Given this list of marker genes Spg21, Gdf7, Nrg3 (neuregulin 3), Wnt4, Kras, Bdnf, Zfp106, Tiam1, Nup62, Fat4, Rala, Ghrhr, Rnf115, Wdr54, Plcg1, Bmncr, Tgfbr2, Nkx3-1, Ins1, Dok5, Ngef, Blvra, Pdgfrb, Dab2, Anks1, Mir210, Hap1, Lox, Il1b (NCBI Gene Id 16176), Sh2d6, Egf, Mst1r, Flt4, Psen2, Bmper, Gas6, Shkbp1, Bcr, Inhbb, Tet1, Sh2d3c, Itgb5, Mir875, Tgfa, Myoc, Nup93, Pelo, Fkbp1a, Fstl3, Pik3cd, Samd10, Mir744, Gpc1, Ncl, Gpr21, Myorg, Crim1, Tgif1, Nrep, Npr1, Mir7-2, Rbpms, Stat5b, Rhoq, Runx2, Lrp4, Ppm1l, Ncoa5, Dll1, Pid1, Ltbp4, Wwtr1, Pdcd6, Dok4, Spry4, Agr2 (anterior gradient 2), Zmiz1, Tiparp, Hip1, Serpina12, Emilin1, Col4a3, Socs2, Gdnf, Cblc, Ccl2, Mir494, Tgfbr3l, Agrn, Vsir, Efnb1, Rab14, Megf8, Foxc2, Robo1, Blvrb, Pik3r1, Hif1a, Neu3, Tmprss6, Zeb2, Nlk, Fgf3, Ephb3, Veph1, Gp6, Lgmn, Rps6kb1, Plekha1, Ovol2, Wasf1, Gper1 (G protein-coupled estrogen receptor 1), Crb2, Nfia, Myof, Ift80, Snca, Zfp950, Nog, Snx6, Twsg1, Frs3, Mvb12b, Zfp703, Schip1, Fbxw8, Casp3, Dcn, Fbn2, Strap, Ryr1, Vwc2, Rtn4, Gucy2f, Dlx5, Flt1, Dmrt1, Cbl, Ptp4a3, Zfp451, Mertk, Appl1, Lat, Bmp8a, Mmp9, Ndrg4, Men1, Skil, Gdf11, D130043K22Rik, Ptpn2, Cidea, Igfbp5, Dlx3, Bcl9l, Hhip, Fgf17, Smoc2, Lrrc32, Cdh3, Prkcd, Syk, Socs4, Ntf5, Gkap1, Abl2, Stat6, Rnf111, Adipor1, Ski, Ptprr, Irs2, Mir16-1, Onecut2, Sfrp2, Bmp5, Smpd3, Acvr1, Sh2b3, Fut8, Pin1rt1, Efna2, Flrt1, Smurf2, Stat5a, Col3a1 (collagen, type III, alpha 1), Hes5 (NCBI Gene Id 15208), Dkk1, Efnb2, Flrt3, Smad9, Nrp2, Lrg1, Fgf18, Ralb (v-ral simian leukemia viral oncogene B), Gnai2, Marcks, Ryk, Wnt3a, Sorbs1, Ppp2r5d, Gata3, Map2k5, Nrtn, Ero1a, Nppc, Slc39a14, Gpld1, Lif, Gcnt2 (glucosaminyl (N-acetyl) transferase 2 (I blood group)), Angpt1, Pdgfa, Zfyve27, Ulk1, Rassf2, Adam9, Alkal1, Fgfrl1, Itgb1, Ceacam2, Fgf22, Snx5, Notch2, Lrig2, Sulf2, Ptpn1, Ar, Rgma, Cdkn1c, Rbpms2, Rbpj, Fgf7, Ros1, Rabgef1, Ephb4, Tmem204, Chst11, Mup5, Tmem100, Txnip, Brms1, Itga3, Zfand5, Pdgfc, Gng7, Ntrk1, Ptk2b, Hjv, Nkx2-1, Dstyk (dual serine/threonine and tyrosine protein kinase), Musk, Lgals9, Tbx20, Fgf6, Sh2b2, Ahi1, Parp1, Nfatc4, Ptprj, Mir125a, Tie1, Suds3, Hspa5, Shc4, Rac1, Grb10, Dnai1, Mapk14, Aspn (asporin), Esr2, Mirlet7d, Hbegf (heparin-binding EGF-like growth factor), Cblb, Mapkapk2, Erfe, F7, Sulf1, Lcp2, Erbb3, Inpp5k, Rapgef2, A1bg (NCBI Gene Id 223599), Pdk4, Sap30, Tmem119, Fgf20 (fibroblast growth factor 20), Ahsg, Sesn3, Fzd4, Map1lc3a, Efna5 (ephrin A5), Ndst1, Arid4a, Rbbp7, Fgfr2, Srsf3, Jcad, Stub1, Tgif2, Vwc2l (NCBI Gene Id 320460), Epha10, Ss18, Scx, Npr2, Pou1f1, Gucy2g, Mup2, Mir329, Nepn, Nr4a3, Tek, Lemd3, Dusp22, Axin1, Sptbn1, Gfra4 (NCBI Gene Id 99308), Phf14, Atf2, Insrr, Adissp, Synj2bp, Ep300, Mir25, Rnf126, Slc2a4, Atp1a3, Acvr2a, Chn1, Zc3h3, Srebf1, Lef1, Pten, Slc2a10, Jak2, Ntrk2, Hgf, Adipoq, Psen1, Tgfb3, Myo1c, Adgra2, Lemd2, Rapgef1, Trp53, Erbb4, Fam89b, Rarres2, Alkal2, Grem2, Fasl, Arid5b, Spred1, Enpp1, Itga1, Mir23a (NCBI Gene Id 387216), Pin1, Apln, Comp (cartilage oligomeric matrix protein), Ints9 (NCBI Gene Id 52529), Mapk1, Smarcc1 (NCBI Gene Id 20588), Agt, Grb2 (growth factor receptor bound protein 2), Itgb6, Mirlet7a-1, Gab2, Pik3r3, Bmp8b, Il17f, Glg1, Fgf16, Tcf7l2, Hck, Fgf14, Mbd5, Igf1, Efna3, Fut7, Akap4, Tob1 (transducer of ErbB-2.1), Pgf, Sos1, Chrdl1, Tspan32, Pmepa1, Nanog, Rab7, Pxn, Gsk3a, Pdgfb, Ror2, Cpne3, Fyn, Dnm2, Sap130, Cripto, Ift88, Map2k1, Stmn1, Pip4k2c, Yes1, Atxn7, Fgfr3, Clec14a, Mstn, Tradd, Iqgap1, Sirt1, Ccn1, Cdkn2b, Efs, Ghr, Mir7-1, Pigr, Nrp1, Stat3, Numa1, Jak3, Dok6, Zdhhc16, Mtmr4, Bmpr1a, Opa1, Zic2, Pakap, Prkd2, Apc, Pik3r2, Zfp423, Grb14, Dok3, Tsc22d1, Dand5 (NCBI Gene Id 23863), Obp2a, Dab2ip, Appl2, Hhex, Fgf2, Tgfb2, Nrg2, Zfand2b, Ldlrad4, Chmp6, Bmp7, Cd2ap, Bcar3, Stk11, Gucy2e, Usp15, Gucy2c (guanylate cyclase 2c), Spry1 (NCBI Gene Id 24063), Snx1, Tfap2b, Hdac1 (NCBI Gene Id 630524), Fbxl15, Mvb12a, Tyro3, Smad5, Htra1, Ucma, Frk, Sox9, Nck2, Lmtk2, Csrnp1, Prkd1 (protein kinase D1), Map3k1, Irs3, Bcar1, Ptk2, Irs1, Pbld2, Fuz, Bace1, Gigyf1, Fstl5, Csf1r, Rela, Smad2, Kcp, Kank1, Tgfb1i1, Dusp3, Il12a, Fgf15, Usp9x, Kl, Hmga1, Col4a2, Flcn, Lifr, Sap30l, Farp1, Cited1, Agtr2, Git1, Ube2o, Mir145a, Ing1, Rhbdf1, Col4a1, Hgs, Amh, Tcf4, Rgs14, Vegfa, Foxd1, Ctdspl2, C1qtnf12, Tgfbr1, Prkcz, Hras, Slc9a6, Snw1, Igfbp4, Sdcbp, Slc39a5, Cdk5r1, Prkcb, Sort1 (NCBI Gene Id 99747), Shcbp1, Afap1l2, Sfrp4, Nptn, Rhbdf2, Slc31a1, Bmp4, Egfr, Ptprt, Mmrn1 (NCBI Gene Id 70945), Stap1, Mirlet7f-2, Dbx2, Sipa1l1, Xbp1, Myo1e, Cd59a, Adgrg1, Scube3, Ppp2r5b, Atxn1, Zcchc12, Esm1, Hipk2, Cfc1, Blk, Crebbp, Akt1, Ing2, Lep, Socs7, Fstl1, Nrg4 (neuregulin 4), Flt3, Wfikkn2, Rps6kb2 (ribosomal protein S6 kinase, polypeptide 2), Anks1b, Prmt1, Gdf5, Eid2, Pdk2, Ptpn12, Myocd, Tmem53 (transmembrane protein 53), Ffar3, Klk8, Pdgfra, Hesx1, Msx2, Zfp640, Selenon, Gdf2, Lyn, Tfap2a, Bmp2, Ltk, Osbpl8, Ptgir, Inppl1, Efna1, Snx25, Adam10, Msx1, Amhr2, Egr1, Pml, Shisa2, Plce1, Ccdc88a, Ceacam1 (CEA cell adhesion molecule 1), Cd63, Col4a5, Kdr, Itga5 (NCBI Gene Id 16402), Igfbp3, Fer, Tsg101, Skor1, Ndn, Sostdc1, Eif4ebp1, Foxo4, Arrb2, Cadm1, Pdpk1, Sema6a, Zfp592, Cav3, Trim33, Grb7, Leprotl1, Caml, Fgf21, Ppara, Kit, Trim71, Fos, Tns2, Mapk8, Braf, Pik3ca, Igf2, Map2k2, Mzb1, Vegfc, Hpgd, Cdh13, Rhod, Prdm16, Itga8, Efemp1, Ret, Smad1, Btc, Ctsd, Epha2, Ptprf, Ercc2, Socs5 (NCBI Gene Id 69052), Itgb8, Cass4, Tspan9, Mir122 (NCBI Gene Id 387232), Wfikkn1, Mup3, Spi1, Col1a2, Csnk2b, Foxc1, Ngly1, Fgr, Trps1, Mmp14, Epha5, Cyfip2, Pdap1, Nedd9, Gfra3, Efna4, Tyk2, Adrm1, Angpt4, Cul7, Mup1, Thbs1, Cnmd, Ndel1, Klb, Col6a1, Gata6, Fam83g, Mcemp1, Creb1, Akt1s1, Fgf8, Nppb, Lats1, Ngf, Furin, Adgre4, Pbld1, Fam20c, Dlx1, Il17rd, Cilp, Igfbp6, Smad4, Zfp128, Gpc3, Fshr, Fam83a, Tgfbr3, Itgb3, Tnf, Cnot9, Onecut1, Bex1, Akap3, Ddx5, Fermt1, Elapor2, Ctnnb1 (catenin beta 1), Abl1, Smad3, Mir143, Tnfaip6, Stxbp4, Fzd1 (NCBI Gene Id 14362), Smad7, Slc2a8, Gpr155, Arid4b, Trim72, Gfra1, Nrg1, Mir382 (microRNA 382), Jak1, Lrp1, Leprot, Pip4k2a, Nck1 (non-catalytic region of tyrosine kinase adaptor protein 1), Sh2b1, Spred2, Col1a1 (collagen, type I, alpha 1), Angpt2, Ltbp1, Inhba, Fnta, Sin3a, Bmp10, Fgfbp3, Zgpat, Pde6h (NCBI Gene Id 78600), Flrt2, Cer1, Chrdl2, Got1, Socs1, Akap7, Spart, Ntf3, Tsc2, Igfbp1, Fgf12, Sinhcaf, Ccn3, Nodal, Ptpre, Hsp90ab1, Epha6, Ccbe1, Axl, Acvr1c, Sost, Mvp, Adamts3, Dgkd, Prkca, Tmem108, Angptl1, Nr1h4, Alk, Chrd, Dact2, Rasl11b, Ndp, Zyx, Socs3, Fst, Lck, Ghsr, Nherf1, Pik3cb, Nppa, Gprc5a, Fgfr4, Ptprk, Zfyve28, Mir130a, Hoxa13, Efnb3, Hivep1, Hes1, Prlr, Peg10, Htra3, Rgmb, Tbx2, Ephb6, Nrros, Dcp1a, Ddr2, Fshb, Smurf1, Myd88, Ptpra, Ctf1, Mirlet7b, Ofd1, Igfbp2, Epha3, Nus1, Plat, Acp4, Ddit4, Gh, Pak1, Foxo1, Mup4, Pde6g, Slc27a4, Sos2, Wnt5a, Hif1an, Zdhhc17, Gab1, Src, Ptpn11, Neo1, Ins2, Ilk, Rbbp4, Zeb1 (zinc finger E-box binding homeobox 1), Mir290a, Clasp2, Raf1, Smad6, Vegfd, Col4a6, Vtn, Pspn, Bmpr2, Adam17, Fgf4, Garem1, Gsk3b, Ankrd26, Sfrp1, Kif16b, Lonp1, Id1, Ereg, Foxh1, Dok7, Ptk6, Tab1, Epha4, Cadm4, Mep1a, Spred3, Bmpr1b, Ephb2, Apod, Cyfip1, Shc1, Vps25, Nrxn1, Pdgfd, Mup11, Cldn5, Akt2, Ift20, Frs2, Bmp6, Met, Mir675, Pparg, Cdh5, Grem1, Slc30a10, Rbm4, Hfe, Shc3, Sh3glb1, Arf4, Pip4k2b, C2cd5, Vps13a, Fgf5, Dsg4, Becn1, Prickle1, Fgf23, Brms1l, Crkl, Etv2, Eif2ak3, Dok1, F3, Cd109, Hip1r, Mmrn2, Adamtsl2, Mirlet7f-1, Mir147, Ston1, Vasn, Sorl1 (sortilin-related receptor, LDLR class A repeats-containing), Sik2, Prkcq, Blnk, Vwa2, Igf1r, Glce, Lrit3, Il12b, Ppm1a, Fam83b, Fbn1, Fgf1, Gata4, Hspb1, Mfn2, Fstl4, Lefty1, Chrna3, Ephb1, Errfi1, Wnt1, Lpxn, Lats2, Sh3tc2, 2610005L07Rik (RIKEN cDNA 2610005L07 gene), Ccn2, Sgpl1, Zbtb7a, Ly6g6e, Phip, Gfra2, Nucks1, Il6st, Ltbp3, Ntrk3, Fermt2, Ext1, Acvr1b, Irs4, Hdac2, Acvr2b, Vegfb, Fgfbp1, Adamts12, Plaur, Areg, Mapk3, Epn2, Fgf10, Epha1, Crk, Dok2, Csf1, Clnk, Csrp3, Diaph1, Gipc1, Prdm14, Cited2, Tnrc6c, Muc20, Atoh8 (NCBI Gene Id 71093), Ddr1, Pdcd4, Map3k7, Dact1, Ark2c, Zfyve9, Cav2, Igsf1, Fgfr1, Nedd4, Tgfb1, Mtcl2, Shc2, Zbtb7b, Eif4ebp2, Gigyf2, Jun, Prkaa1, Ercc1 (excision repair cross-complementing rodent repair deficiency, complementation group 1), Cep57, Folr1, Notch1, Gdf3, Npnt, Arap1, Epha7, Spry2, Artn, Mir145b (microRNA 145b), Ubash3b, Xdh, Ror1, Magi2, Acvrl1, Svep1, Samd12, Nbl1, Epgn, Srms, Ngfr, Rbx1, Vil1, Gdf6, Sox11, Mir181c, Erbb2, Gdf15, Lrp2, Pals1, Gfral, Esr1, Bambi, Churc1, Eng (NCBI Gene Id 99055), Nucb2, Epha8, Skor2, Gucy2d, Cspg4, Ecsit, Plcb1, Fgf9, Mt3, Cav1, Insr, Hrg, Mir185 (NCBI Gene Id 387180), Tom1l1, Diaph2, Ide (insulin degrading enzyme), Adra2a, Creb3l1, Ogt, Mir181d, Fkbp8, here is a description of the gene set: The series of molecular signals initiated by an extracellular ligand binding to a receptor on the surface of the target cell, where the receptor possesses catalytic activity or is closely associated with an enzyme such as a protein kinase, and ending with the regulation of a downstream cellular process, e.g. transcription. Mouse Gene Set: GOBP_ENZYME_LINKED_RECEPTOR_PROTEIN_SIGNALING_PATHWAY species: Mus musculus